The following is a description of a gene set: Mouse Gene Set: GOMF_PASSIVE_TRANSMEMBRANE_TRANSPORTER_ACTIVITY Enables the transfer of a single solute from one side of a membrane to the other by a mechanism involving conformational change, either by facilitated diffusion or in a membrane potential dependent process if the solute is charged. studied in species Mus musculus, and this is the list of marker genes: Micu2, Kcnmb4, Gjc1, Amigo1, mt-Atp8, Apol9b, Rhcg, Gjb1, Fxyd3, Vamp8, Cacnb4, Trpm8, Gabrr3, Bcl2l10, Tmco1, Slc1a5, Gem, Grik5, P2rx3, Cacna1e, Aqp8, Chrnb3, Nrxn3, Clic6, Gjb4, Ano10, Cacng8, Kcnn4, Atp5mc2, Tmc8, Lrrc8d, Htr3a, Clcnka, Grm2, Grid1, Itpr2, Panx1, Kcnab3, Glrb, Nalcn, Kcnh3, Gjb2, Gjc3, Kcnk9, Lrg1, Sumo1, Grin2d, Slc15a1 (solute carrier family 15 (oligopeptide transporter), member 1), Prkcb, Cacna2d2, Grik3, Ywhah, Cacna1c, Atp5pf, Stx7, Kcnn3, Tmem266, Vdac3, Chrnb4, Slc17a7, Gabrd, Ano5, Cacna1g, Sgk1, Tmem38a, Trpm1, Trpv1, Pias3, Lrrc38, Slc26a9, Fxyd6, Best2 (bestrophin 2), Kcnq4, Atp5f1a, Stoml1, Rangrf, Clcn1, Cnih3, Cacna1a, Cacna1s, Slc1a7, Gabra6, Kcnt2, Ghitm, Cnga2, Mcoln3, Calhm1 (calcium homeostasis modulator 1), Atp5f1e, Kcnq3, Ano7, Calm1, Gabrb2, Kcnab2, Scnn1g, Tmc3, Pkd1l1, Cftr, Ano8, Lrrc8c, Gabrp, Vdac1, Fgf12, Cabp5, Nmur2, Rasa3, Cacng4, Clcc1, Chrne, Gria3, Kcnmb3, Ano4, Kcnv2, Gabra2 (gamma-aminobutyric acid type A receptor subunit alpha 2), Cacna1h, Gsdma3, Snta1, Gria1, Trpm6, Ensa, Atp5f1b, Tmc6, Kcnk1, Lamp2, Dlg1, Slc12a2, Gja6, Kcnip1, Chrna10, Chrna5, Tmbim1, Slc24a3, Prkcz, Stx8, Tmem120a, Gja8, Kcnk13, Scn11a, Scn2a, Tmem63c, Atp6v1a, Grin2a, Gpld1, Tmbim4, Slc12a6, Chrna7, Tmc1, Fkbp1b, Trpv3, Cav3, Gsdmc4, Cacna2d1, Bax, Hcn4, Rimbp2, Gje1, Clca3b, Slc1a4, Atp5f1d, Gjd4, Grina, Apol10b, P2rx6, Clic5, Agt, Pkd2l1, Calm3, Kcnh1, Kcnh5, Trpm2, Kcng1, Chrm5, Psen1, Slc24a2, Calhm6, Camk2d, Gsdmc3, Prss8, Trpm4, Slc14a1, Shoc2, Fxyd5, Catsper2, Kcnk5, Cngb3, Atp5mc1, Kcnj11, Slc26a6, Kcna1, Aqp5, Scn3a, Lrrc26, Kcna10, Adrb2, Bcl2l2, Oprm1, Gja4 (gap junction protein, alpha 4), Vti1b, Slc26a7, Gabrg2, Gpd1l, Fgf13, Slc24a4, Kcnj13, Kcnma1, Aqp6, Hvcn1, Aqp9, Cnga4, Lynx1, Atg5lrt, Hcn2, Chrnb2, Trpv2, Asic3, Scn1a, Micu1, Kcnj3, Mip, Slc4a11, Gsdma, Clcn3, Orai3, Gsdmc, Slc26a8, Kcnc4, Tmbim6 (transmembrane BAX inhibitor motif containing 6), Asic4, Gsdme, Grin2c, Gsdmd, Slc17a3, Ano9, Slc9c1, Kcnh4, Kcnk10, Kcnk4, Chrna9, Kcnu1, Kcng3, Slc24a5, Cav1, Smdt1, Ptpn3, Panx3, Kcnip4, Glra4, Chrna1, Grin3b, Bcl2a1d, Wnk1 (WNK lysine deficient protein kinase 1), Kcnh8, Mcoln1, Slc5a3, P2rx1, Clcn5, Trpv5, Cacnb2, Pacc1, Rhag, Kcna7, Trpc6, Scn10a, Gja10, Kcnj12, Wnk2, Cldn17, Cacna1f, Fxyd2, Chrnd, Gja3, Kcnh2, Atp5pd, Mfsd8, Sec61a1, Gjb6, Slc1a1, Kcnc1, Atp6-ps, Kcng4, Cacnb3, Phpt1, Hcn1, Cachd1, Hpcal4, Grin1, Stx1a, Tmem175, Best3, Kcnk16, Rrad, Fgf14, Pdpn, Tmem37, Calhm3, Cacng6, Trpc1, Kcnd2, Bcl2a1b, Kcnip3, Clcn2, Kcnk18, Tmem38b, Mpv17, Cybb, Vdac2, Gria2, Scn4b, Catsper1, Chrna3, Oca2, Stom, Kcna3, Kcnc3, Prss30, Cacna1i, Gpm6a, Pacsin3, Slc24a1, Clcn6, Glrx, Aqp7, Nrxn2, Cldn4, Prf1, Ncs1, Trpc7, Wnk4, Tmem150c, Cacna2d4, Apol9a, Atp5mf, Kcnk7, Slc17a8, Slc30a1, Gja5, Prkg1, Gabrb3, Tnni3, Kcnc2, Calhm5, Grik4, Cacna1b, Gria4, Trpa1, Gabrg3, Gnb2, Gjc2, Lrrc8a, Gabra4, Kcnq1, Ank2, Akt1 (thymoma viral proto-oncogene 1), Gabrr2, Kcnb2, Kcnj8, Tmem109, Grin2b, Aqp4, Kcnj6, Kcnn1, Stimate, Clcnkb, Kcnb1, Ttyh1, Kcnd3, Bcl2, Cacna2d3 (NCBI Gene Id 12294), Slc12a5, Dpp10, Scn3b, Pkd2l2, Kcng2, Trpm5, Asic2, Nedd4l, Aqp11, Kcnj16, Rhbg (Rhesus blood group-associated B glycoprotein), Ttyh2, Itpr3, Calhm4, Atp5pb, Kcnj15, Otop3, Cacng5, Trpc4, Kcnj2, Kcnd1, Orai2, Htr1b, P2rx7, Faim2, Clca3a1, Ryr2, Cnga1, Tspoap1, Fgf11, Bsnd, Grm7, Ryr3, Kcnf1, Apol11a, Itgav, Asic1, Kcnj9, Cd44, Gsdma2 (NCBI Gene Id 78322), Trpc3, Abcc8, Clca2, Trpc5, Nos1, Wnk3, Rem1, Kcne2, Tomm40l, Nalf2, Pex5l, Scn8a, Gpr89, Chrna4, Flna, Trpv4, Kcnk2, Grm3, Pkd1, Snf8, Apol10a, Gabre, Pkd2, Rhd, Aqp3, Trpv6, Itpr1, Kcna4, Gjb3, Pde4d, Cacna1d, Kcne5, Best1 (bestrophin 1), Tmc7, Gja1, Kcnn2, Clic3, Apol11b, Rack1, Mcl1, Bcl2l1, Atp5po, Tomm40, Htr3b, Kcns2, Tmem63b, mt-Atp6, Cacng2, Tmbim7, Chrng, Ano1, Lrrc8b, Kcns1, Hcn3, Ano2, Commd1, Ryr1, Lrrc55, Gsdmc2, Piezo1, Cngb1, Kcnj5, Fxyd4, Tpcn2, Abcc9, Tmem120b, Tpcn1, Anxa6, Clca3a2, Calm2, Panx2, Atp5mc3, Trpc2, Cabp2, Lrrc8e, Ano6, Pkd1l3, Pfpl, Kcna6, Mcu, Kcnmb1, Ccdc51, Tmem63a, Otop1, Fxyd1, Aqp12, Scn7a (sodium channel, voltage-gated, type VII, alpha), Bnip1, Nedd4, Gabrr1, Kcnv1, Slc6a4, Kcnk6, Kcnh7, Cacng1, Gjd3, Sclt1, Mlc1, Kcnip2, Gabra5, Apol8, Scn4a, Bok (BCL2-related ovarian killer), Mcub, Scnn1a, Atp5mg, Kcnk3, Scnn1b, Fxyd7, Kcns3, Atp5me, Catsper4 (cation channel, sperm associated 4), Tmc2, Cacnb1, Kcna5, Bcl2a1c, Scn1b, P2rx4, Arpp19, Aqp2, Sgk3, Grik2, Clcn4, Bcl2a1a, Piezo2, Gabrb1, Kcne3, Kcnmb2, Pkdrej, Kcnj10, Cacng3, Stim2, Nrxn1, Gabrq, Tspan13, Lamp1, P2rx5, Orai1, Grid2, Kcna2, Calhm2, Stim1, Nherf1, Cacng7, Pcsk9, Gabra3, Gabra1, Aqp1, Gabrg1, Cabp4, Asic5, Cnih2, Bak1, Kcnj4, Chrna2, Atp5f1c, Crisp4, Glra2, Kcnab1, Cnga3, Clic4, Scn2b, Clca4a, Gjd2, Lrrc52, Snap25, Glra1, Trpm3, Trpm7, Kcnq2, Grin3a, Sting1, Atp2b4, Kcne1, Kcnh6, Grik1, Kcnk12, Chrnb1, Cabp1, Slc26a11, Chrna6, Mpeg1, Sgk2, Clic1, Akap9, Tmprss3, Rem2 (rad and gem related GTP binding protein 2), Dpp6, Micu3, Kcne4, Nalf1, Clca4b, Kcnj14, Unc80, Mcoln2, Scn5a, Kcnt1, Pkd1l2, Otop2, Tmc5, Ano3, Fkbp1a, Kcnj1, P2rx2, Kcnk15, Clca1 (chloride channel accessory 1), Catsper3, Kcnq5, Scn9a, Gjb5, Glra3, Tmc4 (NCBI Gene Id 353499), Slc17a6, Tmem168, Ywhae, Ttyh3